The following is a description of a gene set: Human Gene Set: HP_OVERGROWTH Overgrowth studied in species Homo sapiens Excessive postnatal growth which may comprise increased weight, increased length, and/or increased head circumference., and this is the list of marker genes: EHMT1, PIK3CA, NFIX, SOST (NCBI Gene Id 8149), KCNQ1OT1, FIBP, NSD1, GPR101, DLK1, PDGFRB, KMT2C, RTL1, DNMT3A, GPC4, NF1, RNF135, SPIN4, HSPG2, ESR1, DICER1, HNRNPK, FBLN5, H3-3B, HRAS, HERC1, SETD2, CDKN1C, EFEMP2, KCNQ1, ARHGEF9, GPC3, MEG3, FAM20A, PTEN, TGFB3, CAMK2A, IGF2, AKT1, HECTD4, EED, EZH2 (enhancer of zeste 2 polycomb repressive complex 2 subunit), PIGA, NRAS (NCBI Gene Id 4893), SUZ12, PIK3R2, KRAS